Given this list of marker genes Ryr2, Ank2, Kcnn2, Cacnb2 (calcium channel, voltage-dependent, beta 2 subunit), Scn5a (NCBI Gene Id 20271), Kcnj5, Flna, Kcnq1, Kcne5, Gja5, Trpm4, Nup155, Scn3b, Kcna5, Cacna1c, here is a description of the gene set: The process that mediates interactions between an atrial cardiomyocyte and its surroundings that contributes to the process of the atrial cardiomyocyte communicating with an AV node cell in cardiac conduction. Encompasses interactions such as signaling or attachment between one cell and another cell, between a cell and an extracellular matrix, or between a cell and any other aspect of its environment. species: Mus musculus Mouse Gene Set: GOBP_ATRIAL_CARDIAC_MUSCLE_CELL_TO_AV_NODE_CELL_COMMUNICATION